Given this list of marker genes Ak2, Guk1, Ak3, Ak1, Ak4, here is a description of the gene set: Mouse Gene Set: GOBP_PURINE_NUCLEOSIDE_DIPHOSPHATE_BIOSYNTHETIC_PROCESS studied in species Mus musculus The chemical reactions and pathways resulting in the formation of purine nucleoside diphosphate, a compound consisting of a purine base linked to a ribose or deoxyribose sugar esterified with diphosphate on the sugar.